Given this list of marker genes TKT, GK, SLC35C1, NEU1, SLC25A13, RPIA, TP53, SKIC3, KLF6, PEX12, IL1B, CASP10, SHPK, SNX14, MANBA, FBP1, KRT18, IL1RN (interleukin 1 receptor antagonist), PIK3CA, GALK1 (galactokinase 1), FGFR2, ACVR1B, GALT, MAN2B1, MUTYH, FOXP2, KHK, GLB1, KRAS, GNPTAB, GALE, IRF1, GAA, SMAD4, STK11, APC, ERBB2, DCXR, OCRL, FUCA1, HEXB, here is a description of the gene set: Abnormal urine carbohydrate level Human Gene Set: HP_ABNORMAL_URINE_CARBOHYDRATE_LEVEL studied in species Homo sapiens Any deviation from the normal concentration of a carbohydrate in the urine.